Given this list of marker genes ABCA4, RDH10, BCO2, DHRS4L1, CYP1B1, DHRS4L2, RBP4, AKR1C1, ALDH8A1, CYP27C1, RPE65, BCO1, RDH11, AKR1C3, RDH13, ALDH1A2, SDR16C5, DHRS4, ALDH1A3, here is a description of the gene set: Human Gene Set: GOBP_RETINAL_METABOLIC_PROCESS The chemical reactions and pathways involving retinal, a compound that plays an important role in the visual process in most vertebrates. In the retina, retinal combines with opsins to form visual pigments. Retinal is one of the forms of vitamin A. species: Homo sapiens